Given this list of marker genes GATA1, HSD17B4, SOX8, SOX9, SCX, NR5A2, FSHR, ARID4A, FLNA, FNDC3A, NTRK1, DMRT1, NUP210L, FER, ABCB1, ATRX, RAB13, ARID4B, here is a description of the gene set: Human Gene Set: GOBP_SERTOLI_CELL_DEVELOPMENT The process whose specific outcome is the progression of a Sertoli cell over time, from its formation to the mature structure. Cell development does not include the steps involved in committing a cell to a Sertoli cell fate. studied in species Homo sapiens